The following is a description of a gene set: studied in species Mus musculus Mouse Gene Set: chr2E1, and this is the list of marker genes: Mir129-2, Gm18165, Or4a79, Mir670hg, Or4a75, Gm18164, Gm13761, Or4a68, Gm13785, Chst1, Gm13817 (predicted gene 13817), Or4c12 (olfactory receptor family 4 subfamily C member 12), Gm13778, Or4c127, Celf1, Gm13889, Mir6999, Rpl30-ps3, Or4c111 (olfactory receptor family 4 subfamily C member 111), Or4c11, Large2, Ddb2, Gm26396, C1qtnf4, Arhgap1, Gm13815, Frey1, Mir7001, Gm13776 (predicted gene 13776), Or4c109, Mir129b, Ndufs3, Or4b13, Gm18953, 2900072N19Rik, Gm13771, Or4c119, Creb3l1, Or4a69, Accs, Syt13, Gm13804, Gm13808, Or4c114 (NCBI Gene Id 258901), Or4c126, Or4c117, Mir670, Or4i1-ps1, Prdm11, Or4c15, Or4c106, Acp2, Ptprjos1 (NCBI Gene Id 71158), Or4p23, Cstpp1, Ptprj, Spi1, 4631405J19Rik, Gm13811, Gm13767 (predicted gene 13767), Or4p8, Or4ad2-ps1, Nr1h3, 4930445B16Rik, Gm13813, Accsl, Harbi1, Rapsn, Or4c3d, Alkbh3os1, Or4c116, Mybpc3, Or4b12, Gm13816, Or4a39, Gm13783, Ptpmt1, Ambra1, Gm13772, Or4c105, Pacsin3, Slc35c1, Or4a81, Gm13814, Or4c52 (NCBI Gene Id 258790), Or4x5-ps1, Psmc3, Zfp408, Or4c35, Ext2, Gm13791, Or4c115, Gm13794, Gm13806, Olfr1266-ps1, Or4c120, Gm5035, Or4a47, Mtch2 (mitochondrial carrier 2), Gm13807, Or4c58, Gm13788, Or4a67, Gm13770, Cd82, Gm13810, Mir7221, Agbl2, Olfr1235-ps1, Gm32514, Gm22313, Or4ae1-ps1 (NCBI Gene Id 404493), Atg13, Or4a71, Arfgap2, Or4c15b, Alx4, Or4c107, Cry2, Gm13809, Gm13786, 2810002D19Rik, Api5, Or4c11b, Gm13768, F2, Or4a78, Or4a74, Or4c110, Or4x12-ps1 (olfactory receptor family 4 subfamily X member 12, pseudogene 1), Or4c122, Mapk8ip1, Or4b1, Itpa-ps1, Or4c3, Or4c124, Ttc17, Or4b1c, Gm13799, Or4a27, Fnbp4, Gm1335, Or4c113, Or4c123, Or4a73 (NCBI Gene Id 258788), Gm13798, Or4c12b, Mdk, Or4c125, Or4x15, Trp53i11, Chrm4, Dgkz, Or4c104, Slc39a13, Gm13818, Or4x11, Madd, Lrp4, Or4a76, Or4a80, Gm4222, Tspan18, Or4c29, Mir1955, Gm13777, Gm10804, Or4c11c, Or4c1, Snord67, Ckap5, Kbtbd4, Gm13803, Or4a15, Gm13787, Mir7000, Or4c118, Mir7222, D930015M05Rik, Or4b1d, Or4c121, Pex16, Or4b1b, Gm17076, Alkbh3, Gm13793, Or4a2, Gm17075, Gm24318, Or4x18, Or4x13, Or4c108, Hsd17b12, Gm23390, Nup160, Or4a72, Gm13812, Or4c112, Lrrc4c, Or4c10b, Gm18166, Or4a77, Or4a70, Or4c10, Phf21a, Or4x6